The following is a description of a gene set: Genes predicted to be targets of miRBase v22 microRNA hsa-miR-550b-2-5p in miRDB v6.0 with MirTarget v4 prediction scores > 80 (high confidence targets). studied in species Homo sapiens Human Gene Set: MIR550B_2_5P from publication Chen Y, Wang X (PMID 31504780), and this is the list of marker genes: XKR6, ADCY1, CYP27B1, ACTR3, KBTBD8, CADM2, TBL1XR1, ULK2, FAM120A, WDR26, RSRC1, ID4, USP1, HINT3, PTPN21, FAM180B, SAMD12, NDUFAF4, TSTD2, DSCAML1, ADAM10 (ADAM metallopeptidase domain 10), ATF2, B3GALT2, CACNA1B, NCBP1, CPNE4, ANKRD13B, CPEB3, USP3, NXPH1, SCN11A, LRP1B, CX3CR1, KIAA1217, GSK3B, NRXN1, PHOX2B, EIF2S3, YIPF3, PBX1, RFESD, SEPTIN8, TMEM30B, KLF6, STXBP5 (syntaxin binding protein 5), CDCA7, MAP1LC3B, MYH2